Given this list of marker genes PSME3, CD93, BOP1, COX6A2, FOXN2 (forkhead box N2), NEDD4, DOLPP1, ABCD1, TAX1BP3, PTGR1, WDR13, LHX8, QKI, EMID1, GALK1, CFP, PAX2, AKAP17A, UCK2, ACY1, VPS45, CD36, VPREB3, RELN, GRID2, HBS1L, USF2, MARCKS, MEA1, ATP1B1, STXBP2, LHB (luteinizing hormone subunit beta), HCK, MYB, SNRPC, CDC45, ZFPM1, PEPD, HES1, MYL4, PPP1R14B, TGFB1, PLD4, LIPC, GH1, CCND2, RBP4 (retinol binding protein 4), ATP5F1C, here is a description of the gene set: Human Gene Set: HOFFMANN_IMMATURE_TO_MATURE_B_LYMPHOCYTE_DN Gene expression profiles of five consecutive stages of mouse B cell development were generated with high-density oligonucleotide arrays from as few as 2 x 10(4) ex vivo isolated and flow-cytometrically purified cells. Between 2.8% and 6.8% of all genes change on differentiation from one cellular stage to the next by at least twofold. The entire pathway involves differential expression of 10.7% of all genes. Previously known expression patterns of genes (like surrogate light chain, RAG-1/2, MHC class II, mel-14 antigen) are confirmed. The gene expression patterns of the proliferating pre-BI and large pre-BII cells on the one hand, and the resting immature and mature B cells on the other hand, are most similar to each other. Small pre-BII cells display a pattern that is transitional between these two groups. Most of the genes expressed in early precursors are involved in general processes, like protein folding or cell cycle regulation, whereas more mature precursors express genes involved in more specific molecular programs (cell surface receptors, secreted factors, and adhesion molecules, among others). Between 19 and genes share a given expression pattern. Combining knowledge about gene function and expression pattern allows identification of novel candidate genes potentially involved in self-maintenance of pre-BI cells, allelic exclusion and pre-B cell receptor signaling in large pre BII cells, cell-cycle arrest of small pre-BII cells, propensity toward apoptosis or anergization in immature B cells, propensity toward cell division and activation in mature B cells, and stage-specific interactions with stromal cells in the bone marrow. from publication Hoffmann R, Seidl T, Neeb M, Rolink A, Melchers F (PMID 11779835) Genes down-regulated during differentiation of immature to mature B lymphocyte. studied in species Mus musculus